The following is a description of a gene set: from publication Durant L, Watford WT, Ramos HL, Laurence A, Vahedi G, Wei L, Takahashi H, Sun HW, Kanno Y, Powrie F, O'Shea JJ (PMID 20493732) STAT3, an essential transcription factor with pleiotropic functions, plays critical roles in the pathogenesis of autoimmunity. Despite recent data linking STAT3 with inflammatory bowel disease, exactly how it contributes to chronic intestinal inflammation is not known. Using a T cell transfer model of colitis we found that STAT3 expression in T cells was essential for the induction of both colitis and systemic inflammation. STAT3 was critical in modulating the balance of T helper 17 (Th17) and regulatory T (Treg) cells, as well as in promoting CD4+ T cell proliferation. We used chromatin immunoprecipitation and massive parallel sequencing (ChIP-Seq) to define the genome-wide targets of STAT3 in CD4+ T cells. We found that STAT3 bound to multiple genes involved in Th17 cell differentiation, cell activation, proliferation and survival, regulating both expression and epigenetic modifications. Thus, STAT3 orchestrates multiple critical aspects of T cell function in inflammation and homeostasis. Genes down-regulated in CD4 T cells with STAT3 knockout: medium versus TGF beta and IL6. studied in species Homo sapiens Human Gene Set: GSE21670_UNTREATED_VS_TGFB_IL6_TREATED_STAT3_KO_CD4_TCELL_DN, and this is the list of marker genes: IL2RG, ZNF23, DONSON, NPRL2, SKIC2, ACTR3, LBR, DNAJA4, MLLT6, SEC61G, FBXO17, P4HTM, COMMD8, CRYBG1, CYTIP, CD53, IFNAR2, ITGAL, CFAP418, KLHL28, ALDH3A2, DNPEP, SAMTOR, COP1, KLF2, CD3G, GSE1, UBE2G1, GPD1L, RPS29, SAT1, AKIRIN1, SYNE1 (spectrin repeat containing nuclear envelope protein 1), PRPF39, ZDHHC20, SDHC, PSENEN, INO80D, DCAF1, DGKZ, SMPD5, SPG21 (NCBI Gene Id 51324), SMAP2, PHF1, RMND5A, BLTP1, NDUFA6, ARHGAP4, ASCC1, RPL11, UNC13D, SIPA1, SGPL1, PSAP, CBL, RMND1, ROCK1 (NCBI Gene Id 6093), AAK1, SATB1, BBS4, NSF, MTA2, PI4KB, DNAAF5, DOK2, KRCC1, TPT1, TMEM134, S1PR1, RCSD1, SPTBN1, MTSS1, PTBP3, CD8B, AAMP, TMEM71, SNAPC1, SPSB3, LAMTOR4, S100A10, MYLIP, PNPLA7, SH2D1A, UBE2D1, CHFR (NCBI Gene Id 56732), SMC4, HNRNPL, HERPUD2, ADD3, PITPNA, FYB1, C9orf78, PTPRCAP, NCK1, N4BP2L2, TAPT1, ZHX2, KAT8, TMEM184C, CARD11, RB1CC1, MSN, TECR, MBNL1, RBM25, RBM3, PPP2R5A, YWHAZ, PFDN2, CNTRL, BTF3, SSU72 (NCBI Gene Id 79588), TRRAP, DAPK3, CCND3, ALKBH6 (alkB homolog 6), MICOS13, FLT3LG, MED13, RNF220, RABGGTA, ARHGAP18, SMDT1, KDM3B, SMURF1, LMO4, MLX, TACC1, TMX4, INPP5D, SLC37A1, NADSYN1, NFKBIE, YIPF4, IKZF1, TTC14, CD7, UBL7, NPC2 (NCBI Gene Id 10577), MEX3D, DNAJB13 (DnaJ heat shock protein family (Hsp40) member B13), ITGAE, ACSS2, ITGB2, SDCBP2, STAT3, SLC12A7, ATP1B3, MAP4K2, YME1L1, STAG2, AHNAK, STK26, CAST, RPL23, UBE2S, IFT80, LRRC8C, TRIM23, STAT4, SUSD3, ANXA6, RAB6A, MTFR1L, TSPYL2, NR2C2AP, RAP1A, CD2, UBE2B, ARFGEF1, TMOD3, RPS27, HLA-C (NCBI Gene Id 5674), RSF1, TK2 (thymidine kinase 2, NCBI Gene Id 7084), HEXB, EIF3K, PARP4, PLEKHG2, HUWE1, NSA2, CNPPD1, MTHFS, CCAR2, ABHD17B, FBXO38, FLI1, PSD4, HSP90B1 (NCBI Gene Id 7184), LMBRD1, LCK, EAF1, DPP4, JPT1, ABCG1, SEC22B, RUNX3, RCBTB2, COX20, SARAF